Given this list of marker genes Polr3b, Ice1, Zc3h8, Snapc3, Ell, Ice2, Snapc5, Snapc1, Snapc4, here is a description of the gene set: The synthesis of small nuclear RNA (snRNA) from a DNA template by RNA Polymerase III (Pol III), originating at a Pol III promoter. Mouse Gene Set: GOBP_SNRNA_TRANSCRIPTION_BY_RNA_POLYMERASE_III species: Mus musculus